Given this list of marker genes IFT25, DYNC1I2, IFT140, DYNLT3, IFT122, DYNLT1, DYNLRB1, DYNC2LI1, DYNLL2, IFT80, WDR19, IFT22, WDR35, DYNLT2B, DYNLRB2, DYNC1LI2, DYNC2H1, IFT43, DYNC1H1, DYNC2I1, IFT81, DYNC1I1, IFT46, IFT27, DYNLL1, DYNC1LI1, DYNC2I2, here is a description of the gene set: Intraflagellar transport proteins binding to dynein studied in species Homo sapiens Human Gene Set: WP_INTRAFLAGELLAR_TRANSPORT_PROTEINS_BINDING_TO_DYNEIN